The following is a description of a gene set: Binds to and stops, prevents or reduces the activity of ribonuclease. species: Homo sapiens Human Gene Set: GOMF_RIBONUCLEASE_INHIBITOR_ACTIVITY, and this is the list of marker genes: UBE3D, TMBIM6, BRAT1, RNH1, ABCE1